The following is a description of a gene set: Hypomorphic mutations in the zinc finger domain of NF-kappaB essential modulator (NEMO) cause X-linked hyper-IgM syndrome with ectodermal dysplasia (XHM-ED). Here we report that patient B cells are characterized by an absence of Ig somatic hypermutation (SHM) and defective class switch recombination (CSR) despite normal induction of activation-induced cytidine deaminase (AID) and Iepsilon-Cepsilon transcripts. This indicates that AID expression alone is insufficient to support neutralizing antibody responses. Furthermore, we show that patient B cells stimulated with CD40 ligand are impaired in both p65 and c-Rel activation, and whereas addition of IL-4 can enhance p65 activity, c-Rel activity remains deficient. This suggests that these NF-kappaB components have different activation requirements and that IL-4 can augment some but not all NEMO-dependent NF-kappaB signaling. Finally, using microarray analysis of patient B cells we identified downstream effects of impaired NF-kappaB activation and candidate factors that may be necessary for CSR and SHM in B cells. studied in species Homo sapiens from publication Jain A, Ma CA, Lopez-Granados E, Means G, Brady W, Orange JS, Liu S, Holland S, Derry JM (PMID 15578091) Genes abnormally regulated in response to CD40L and IL4 stimulation of B lymphocytes from patients with a hypomorphic mutation of IKBKG. Human Gene Set: JAIN_NFKB_SIGNALING, and this is the list of marker genes: STK4, RNF5, NAP1L1, TAP2, PREPL (prolyl endopeptidase like), TFAP4, APRT, SNX4, BNIP3, ZNF195, MYC, CTSC, PSPH, ZNF415, PRR3, XPO7, PEX14, PLA2G4C, BCAT2, ZZZ3, ARMC6, PAWR, VEGFA, UCHL3, HDDC2, PSMG1, MRE11, JAK2, FLT1, TM7SF2, ENSG00000260917, TICAM1, DDX46 (NCBI Gene Id 9879), SYMPK, SLC29A1, ZNRD2, MED1, IPO8, POLA1, HK2, ORC5, DECR1, SMG7, GBA1, NOC2L, PLAU, CBX3, ALG3, LIG3, SPHK2, MPHOSPH9, RIDA, METAP1, CLNS1A, TPD52L2, TRMT1, GATB, PMVK, ARSB, LMAN2, ASCC3, ITPA, RAD50, LAS1L, DCTN1, PSMA2, CLUH, FBL, DDX42, CA2 (NCBI Gene Id 760), LIG4, ZNF230, RCC1, PTPN7, SLC23A2